The following is a description of a gene set: Human Gene Set: DESCARTES_MAIN_FETAL_EXCITATORY_NEURONS Marker genes curated from the annotated cluster as represented in the Descartes Human Gene Expression During Development database. from publication Cao J, O'Day DR, Pliner HA, Kingsley PD, Deng M, Daza RM, Zager MA, Aldinger KA, Blecher-Gonen R, Zhang F, Spielmann M, Palis J, Doherty D, Steemers FJ, Glass IA, Trapnell C, Shendure J (PMID 33184181) studied in species Homo sapiens The gene expression program underlying the specification of human cell types is of fundamental interest. The study authors generated human cell atlases of gene expression and chromatin accessibility in fetal tissues. For gene expression, the study authors applied three-level combinatorial indexing to >110 samples representing 15 organs, ultimately profiling ~4 million single cells. The study authors leveraged the literature and other atlases to identify and annotate hundreds of cell types and subtypes, both within and across tissues. Our analyses focused on organ-specific specializations of broadly distributed cell types (such as blood, endothelial, and epithelial), sites of fetal erythropoiesis (which notably included the adrenal gland), and integration with mouse developmental atlases (such as conserved specification of blood cells). These data represent a rich resource for the exploration of in vivo human gene expression in diverse tissues and cell types., and this is the list of marker genes: SPIRE1, ENSG00000271860, RNU6-904P, LRRC7-AS1, RNU6-503P, MLLT3, ARHGAP15-AS1, RNU1-47P, SOX5, FOXG1-AS1, RNF182, LINC01965, RN7SL217P, LRRC7, PANTR1